The following is a description of a gene set: A loss-of-function mutation in HHAT that abrogates palmitoylation of Hh ligand is associated with Syndromic 46, XY Disorder of Sex Development, which results in testis dysgenesis. part of: Hh mutants abrogate ligand secretion Reactome Pathway: HHAT G278V doesn't palmitoylate Hh-Np species: Homo sapiens, and this is the list of marker genes: DHH, IHH, SHH, HHAT